Given this list of marker genes PRKDC, XRCC5 (NCBI Gene Id 7520), POLM (DNA polymerase mu), RAG2, XRCC4, XRCC6, NHEJ1, DCLRE1C, POLL, LIG4, DNTT, RAG1, here is a description of the gene set: species: Homo sapiens Pathway Definition from KEGG: RAG1+RAG2 -> Ku == DNAPKC -> DNAPK+ARTEMIS -> DNAPK+POLX -> DNAPK == LIG4+XRCC4+XLF V(D)J recombination. Pathway ID: N01467. Pathway type: Reference. Pathway class: nt06506 Double-strand break repair. Human Gene Set: KEGG_MEDICUS_REFERENCE_V_D_J_RECOMBINATION